Given this list of marker genes Gm2042, Amot, Dcp2, Pacsin2, Exosc1, Dnase2b, Gpc6, Tcaim, Cd226, Flt3, Zfp2, Ccr3, Cand1, Trpm1, Clca4b, Magi3, Lias, Gpr82, Trmt1l, Nckap1, Atp11c, Slc2a13, Camk4, Tmem237, Fam120a, Capza1, Pcdhb14, U2af1, Rlim, Ifi209, Serpinf2, Prkar2b, Sft2d3, Bpnt2, Fzd2, Gbp8, Wdr48 (WD repeat domain 48), Pycard, Eif4e, Zdhhc21, Abhd13, Tut4, Otud6b, Mob1b, Tmem33, here is a description of the gene set: Mouse Gene Set: MIR_34B_3P from publication Chen Y, Wang X (PMID 31504780) species: Mus musculus Genes predicted to be targets of miRBase v22 microRNA mmu_miR_34b_3p in miRDB v6.0 with MirTarget v4 prediction scores > 80 (high confidence targets).